The following is a description of a gene set: from publication Ikeda S, He A, Kong SW, Lu J, Bejar R, Bodyak N, Lee KH, Ma Q, Kang PM, Golub TR, Pu WT (PMID 19188439) Human Gene Set: IKEDA_MIR30_TARGETS_UP species: Mus musculus Genes up-regulated in hypertrophic hearts (due to expression of constitutively active form of PPP3CA) and predicted to be targets of miR-30 microRNA. Calcium signaling is a central regulator of cardiomyocyte growth and function. Calmodulin is a critical mediator of calcium signals. Because the amount of calmodulin within cardiomyocytes is limiting, the precise control of calmodulin expression is important for the regulation of calcium signaling. In this study, we show for the first time that calmodulin levels are regulated posttranscriptionally in heart failure. The cardiomyocyte-restricted microRNA miR-1 inhibited the translation of calmodulin-encoding mRNAs via highly conserved target sites within their 3' untranslated regions. In keeping with its effect on calmodulin expression, miR-1 downregulated calcium-calmodulin signaling through calcineurin to NFAT. miR-1 also negatively regulated the expression of Mef2a and Gata4, key transcription factors that mediate calcium-dependent changes in gene expression. Consistent with the downregulation of these hypertrophy-associated genes, miR-1 attenuated cardiomyocyte hypertrophy in cultured neonatal rat cardiomyocytes and in the intact adult heart. Our data indicate that miR-1 regulates cardiomyocyte growth responses by negatively regulating the calcium signaling components calmodulin, Mef2a, and Gata4., and this is the list of marker genes: PPP1R12A, UBE2J1, YWHAZ, GNA13, MARCKS, ADGRL3, USP15, KDM3A, TFDP1, SSBP2, IRS1, TNRC6A, BNC2 (basonuclin zinc finger protein 2), UBE2D2, MYH10, DTNA, BCL2, FNDC3A, ITSN1, ACTN1, MAN1A2, USP47, GFPT2, SNAI1, SON (NCBI Gene Id 84155), RRAD, PHTF2, JUN (Jun proto-oncogene, AP-1 transcription factor subunit), DPYSL2, ACVR1, NEDD4, SCAF4, ARF4, RAPH1, DDX46, LRRC8D, CDK6, ELL, NOVA1, B4GALT5, PPFIA1, SLC6A6, CNOT6, VKORC1L1, RNF44, DDAH1, XPR1, GALNT7, EPC2, PIP4K2A, SEC23A, SLC4A7, HIC2, CHD9, RAI14, ATP2B1, PAPOLA, MAP4K4, MAF, RASA1, PTBP3, SPPL3, CAST, CPEB2, SOCS6, BECN1, LRRC17, LARGE1, CALM1, P4HA1, UBE2V2 (ubiquitin conjugating enzyme E2 V2), MAML1, CAPZA1, CPEB4, CPNE8, PELI1, ASAP1 (NCBI Gene Id 56237), XPO1, CFL2 (NCBI Gene Id 1073), CELF2, FNDC3B, NRIP1, GTF2H1, ELMO1, SEMA6D, SEMA3A, RAP2C, IER5, WDR7, TBC1D15, PI4K2B, TAOK1, NCAM1, CCND2, CSNK1G1, ARID4B, IRS2, PDCD10, BDNF, CCPG1, NRBF2, CLOCK, KRAS, AP3S1, DMD, WDR44, NFIB, GNAO1, USP34, PTPN2, ARHGEF6, PLCB4, GOLGA4, HDGFL3, NFAT5, ARID4A